Given this list of marker genes IPO7, AOC3, CXXC4, PEDS1-UBE2V1, ACSL6, UBE2V1, POLDIP3, SOX9, B4GALT2, SPTBN4, TET3, CNGB3, FAM241B (family with sequence similarity 241 member B), MAST3, here is a description of the gene set: Human Gene Set: MIR6795_3P studied in species Homo sapiens Genes predicted to be targets of miRBase v22 microRNA hsa-miR-6795-3p in miRDB v6.0 with MirTarget v4 prediction scores > 80 (high confidence targets). from publication Chen Y, Wang X (PMID 31504780)